The following is a description of a gene set: Elastic fibre formation species: Mus musculus Mouse Gene Set: REACTOME_ELASTIC_FIBRE_FORMATION, and this is the list of marker genes: Ltbp4, Furin, Eln, Itgb8, Tgfb2, Fbln5, Emilin3, Loxl1 (lysyl oxidase-like 1), Fbln2, Lox, Itgb3, Itga8, Tgfb1, Itgb6, Loxl3, Fbn1, Bmp4 (NCBI Gene Id 12159), Emilin1, Tgfb3, Gdf5, Itgav, Ltbp2, Mfap5, Mfap2, Bmp10, Efemp2, Ltbp3, Bmp2, Loxl4, Itga5, Vtn, Ltbp1, Emilin2 (elastin microfibril interfacer 2, NCBI Gene Id 246707), Bmp7, Fn1, Itgb1, Mfap4, Loxl2, Fbn2